The following is a description of a gene set: Human Gene Set: RBM17_TARGET_GENES studied in species Homo sapiens Genes containing one or more binding sites for (RBM17) in their promoter regions (TSS -1000,+100 bp) as identified by GTRD version 20.06 ChIP-seq harmonization. from publication Yevshin I, Sharipov R, Kolmykov S, Kondrakhin Y, Kolpakov F (PMID 30445619), and this is the list of marker genes: MIR1538, NSFL1C, NFAT5, NCBP3, KMT2A, AVL9, RABEP1